The following is a description of a gene set: Enables the transmembrane transfer of a potassium cation by a channel that opens when a calcium cation has been bound by the channel complex or one of its constituent parts. species: Homo sapiens Human Gene Set: GOMF_CALCIUM_ACTIVATED_POTASSIUM_CHANNEL_ACTIVITY, and this is the list of marker genes: KCNMB4, KCNU1, CCT8L2, KCNMB1, KCNN3, KCNK18, PKD2L1, KCNN1, KCNMA1, KCNMB2, KCNN4, KCNMB3, KCNN2